Given this list of marker genes Eya4, Fyn, Grina, Tcf7l2, Ndufa13, G2e3, Src, Il1b, Ptpn1, Ar, Prdx2, Csnk2a1, Eif2ak3, Ppia, Marchf7, Gpx1, Unc5b, Bmi1, Avp, Rb1cc1, Dnaja1, Snai2, Xbp1, Nol3, Bdkrb2, Gdnf, Uri1, Fgb, Herpud1, Meis3, Scg2, Tert (NCBI Gene Id 21752), Mmp9, Fignl1, Wfs1, Tnfaip3, Serpine1, Raf1, Ghitm, Lrrk2, Hspb1, Syvn1, Pink1, Rps6kb1, Il10, Hif1a, Fzd9, Fgf10, Wnt16, Tmem14a, Mdm4, Il7, Mrtfa, Gfral, Ern1, Bcl2l1, Gata4, Sfrp2, Slc25a5, Ybx3 (Y box protein 3), Pcgf2, Zmynd11, Mpv17l (Mpv17 transgene, kidney disease mutant-like), Gata1, Prelid1, Ppef2, Peli3, Mif, Itgav, Il19, Trap1, Arrb2, Gclc, Gnai3, Ikbkg, Atf4, Noc2l, Hmox1, Slc25a4, Gas1, Pik3cb, Sod2, Dab2, Cep63, Gnai2, Csf2, Tnfsf4, Map2k5, Kdm1a, Hspa1b, Tnfrsf22, Zfp385a, Cdk11b, Eya2, Sgk3, Cdkn2d, Hdac1, Psen1, Psen2, Icam1, Ddias, Nanos3, Parl, Lgals3, Acvr1, Ndufs3, Eif2a, Eno1b, Lmna, Fxn, Bcl2l10, Itga6, Bcl2l12, Bmp4, Hdac2, Hells, Ctnna1, Mapk7, Gstp-ps, Tmbim1, Ddx3x, Cth, Mdm2, Mfn2 (mitofusin 2), Pycr1, Cx3cl1, Usp47, Nme5, Eya1, Epo, Pak5, Agap2, Ier3, Mcl1, Sh3rf1, Nr4a2, Igf1 (insulin-like growth factor 1), Tnfrsf4, Rela, Maz, Tgfbr1, Bcl2l2, Rtkn2, Gstp2, Ripk1, Triap1, Creb3, Yap1, Ell3, Itprip, Brca1, Wnt1, Aatf, Vdac2, Nog (noggin), Tmbim6, Hgf, Gcg, Pdx1, Eno1, Cxcl12, Qars1, Creb3l1, Nrp1, Slc25a31, Gclm, Il4, Nono (non-POU-domain-containing, octamer binding protein), Vegfa, Akt1, Col2a1, Fzd1, Ing2, Fga, Igbp1, Rb1, Bok, Fcmr, Cd74, Bid, Tnf, Mnt, Ctnnb1, Faim, Faim2, Tnfrsf23, Pea15a, Psmd10, Birc6, Higd1a, Nfe2l2, Bdnf, Ppif, Tmem161a, Rffl, Cx3cr1, Gsk3b, Stradb, Acaa2, Fgg, Cttn, Asah2, Prkn, Ccar2, Kdm6a, Gstp3, Gstp1, Nrg1, Tpt1, Faiml, Park7, Trim32, Psme3, Rrn3, Mapk8ip2, Sh3glb1, Cflar, Snai1, Bax, Bcl2, Txndc12, Wnt4, Selenos, Cd44, Muc1, Eya3, Rnf34, Fbxo7, Phip, Clu, Map2k1, Plaur, Bmf, Atad5, Opa1, Rrm2b, Rack1, Map3k7, Madd, Ackr3, Hyou1 (NCBI Gene Id 58204), Mapk8ip1, D1Pas1, Ivns1abp, Hmgb2, Sirt1, Siah2, Bag5, Fgf2, Armc10, Htt, Bak1, Pam16, Klf4, Pttg1ip, Slc35f6, Ptgs2, here is a description of the gene set: Any process that stops, prevents or reduces the frequency, rate or extent of apoptotic signaling pathway. Mouse Gene Set: GOBP_NEGATIVE_REGULATION_OF_APOPTOTIC_SIGNALING_PATHWAY studied in species Mus musculus